The following is a description of a gene set: Any process that modulates the frequency, rate or extent of long-chain fatty acid import into a cell. species: Mus musculus Mouse Gene Set: GOBP_REGULATION_OF_LONG_CHAIN_FATTY_ACID_IMPORT_INTO_CELL, and this is the list of marker genes: Acsl5, Acsl6, Acsl1, Akt2, Fabp3, Eprs1, Thbs1, Akt1, Irs2